The following is a description of a gene set: species: Homo sapiens Human Gene Set: HP_ABNORMAL_BASAL_GANGLIA_MORPHOLOGY Abnormality of the basal ganglia. Abnormal basal ganglia morphology, and this is the list of marker genes: SUCLA2, ATR (ATR serine/threonine kinase), ADH1C, NANS, COX15, GCDH, CP, PDHX, ASNS, GBA1, SLC2A3, ATXN3, TBP, NUP62 (NCBI Gene Id 51551), LONP1, MT-ND1, CSPP1, SCO2, CASR, CNTNAP1, CYB5A, ATP13A2, FBXO7, AUH, FAM111A, NDUFS1, ERCC3 (NCBI Gene Id 2071), CYP2U1, HSD17B10, RNASEH2B, FTL, PDGFRB (NCBI Gene Id 5159), PRNP, TYROBP (transmembrane immune signaling adaptor TYROBP), SLC30A10, SNCAIP, GJA1, NUDT2, IVD, PNPT1, SAMHD1, VRK1, MT-ND2, PSMB9, LRPPRC, ALG2, JPH3, MT-ND4, CMPK2, SLC20A2, PDE10A, MT-ND5, TACO1, KIAA0586, KCNQ2, MMUT, MT-TW, VPS13A, TUBB2B, FASTKD2, NDUFS4, OPA1, MICU1, SNCA, WDR45, SLC44A1, MYORG, ASL, PSMB8, FA2H, RNASEH2A, MT-TQ, NDE1, ABCB7, GTPBP3, PDE8B, SLC46A1, KMT2B (NCBI Gene Id 9757), CAMSAP1, CYB5R3, ASPA, TREX1, ERCC6, MECR, PANK2, FTH1, DLAT, ATXN8OS, AP1S2, GFAP, MRPL39, IFIH1, NDUFAF5, RANBP2, MAPT, PRKN, GTPBP2, GNAS, GCH1, ISG15, MT-ATP6, PLA2G6, ATXN2, RFT1, CA2, LSM11, NAA60, IMPDH2, TK2, MT-TV, FDXR, BSCL2, DENND5A, MT-TH, ADAR, SNORD118, PDHA1, RBBP8, FOXP2, CPT2, GLI3, IDH1, MT-ND6, DCX, TBCE, GFM1, COQ8A, CLPB, ETHE1, TUBA1A, C19orf12, TIMM8A, POLR3A, HIBCH, SLC25A46, MT-TS2, OPHN1, SPG11, SUCLG1 (succinate-CoA ligase GDP/ADP-forming subunit alpha), AGO1, GLB1, NEK1, NADK2, MT-CO2, NDUFAF6, ERCC8, CYP27A1, VPS11, MT-CO1, LRRK2, HTRA1, AIFM1, NR4A2, PDGFB, VPS41, RNASEH2C, PDSS2, PSMG2, FARS2, JAM2, TBCK, VPS16, MT-TK, MT-TT, MT-ND3, TREM2, RNU7-1, GSX2, EXOSC2, POLR2A, SLC19A3, DNAJC19, MFF, TUBB3, MT-CO3, NUP54 (NCBI Gene Id 53371), ACVR1, HTT, COASY, DNM1L, ESAM, ERCC4, ZEB2, GATA3, GNA11, MT-TF, MT-TL1, XPR1, TUBB